The following is a description of a gene set: studied in species Homo sapiens IGF-IGF1R-PI3K signaling pathway. Pathway ID: N00582. Pathway type: Reference. Pathway class: nt06168 Herpes simplex virus 1 (HSV-1). Pathway Definition from KEGG: IGF1 -> IGF1R -> PI3K -> PIP3 -> AKT -| (TSC1+TSC2) -| RHEB -> MTOR -| EIF4EBP1 Human Gene Set: KEGG_MEDICUS_REFERENCE_IGF_IGF1R_PI3K_SIGNALING_PATHWAY, and this is the list of marker genes: AKT3, AKT1, IGF1R, PIK3CA, EIF4EBP1, IGF1, TSC2 (TSC complex subunit 2), AKT2, TSC1, RHEB, PIK3CD, MTOR, PIK3CB